The following is a description of a gene set: Transcription regulation during the cell cycle is crucial for ensuring genes are expressed at the right time and in the correct amounts, coordinating key processes like DNA replication, mitosis, and cell division. In our study, studied in species Homo sapiens Human Gene Set: PULVER_FOREY_CELLCYCLE_PEAKING_S2 Genes whose expression fluctuates during the cell cycle (pVal < 0.05) and peaks in late S (S2) in K562, and this is the list of marker genes: CNNM3, ITM2A, ALDH1A2, CCDC43, MAP3K1, SPC24, FARS2 (phenylalanyl-tRNA synthetase 2, mitochondrial), GPR55, DHRS13, GPATCH8, CENPO, HAUS4, PBRM1, THAP11, RBM6, GMEB1, DNAJB12, MSH5, SMC1A, LINC01804, PTPN11, CYB5B, PCNP, XPO6, XRCC1, PPP5C, SUSD1, TNRC6C, IWS1, RNF213, GABPB2, BNIP1, ASAP2, H1-5, CZIB, STAT3, PRKCQ, ANKRD13A, BNIP3, TFIP11, SCG5, RAD54L2, PPP6R3, WASF1, CEP128, TRDMT1, PLIN2, SLC1A5, POP1, PANK4, PPP2R3C, AKAP8, SLC1A4, ZNF653, CTCFL, STX2, TTC31, ADARB1, CMC2, TMEM98, MRPL37, AP2A1, AARS2, CDK4, MYB, LRP8, CENPJ, ADRA1D, AGO2, RAVER1, DOLPP1, GRIN1, HROB, NONO, METTL3, DDX17, ANP32B, TRIP13, RNF168, FBXO48, HAUS5, STK35, KAT6A, CCDC22, PUF60, GEMIN4, SUMO3, TNFRSF1B, CPNE2, MTO1, PXMP4, ELP6, EEF1A2, NUP42, CHAC1 (ChaC glutathione specific gamma-glutamylcyclotransferase 1), TUBB, NEMP2, CDK5RAP2, UTP25, CTCF, FBXL14, LRRC8D, TYMSOS, GID8, HAUS8, NAT10 (N-acetyltransferase 10, NCBI Gene Id 79715), KIF15, PIP4P1, KAT5, SENP1, AP5S1, SPC25, DENND4B, GGA3, PEG10, CHRAC1, UBR4, SAE1, SEMA4D, TEDC1, SPOP, QSOX2, SF3A2, TRNAU1AP, JOSD1, NSD2, FAF2, H2AZ1, AMOTL1, GRK2, KATNB1, KEAP1, CBFB, H2AC21, GBF1, ZNF784, ZNF764, LIN9, SLC43A3, H3C4, ATF6, NUP107, TMEM39B, LUC7L, EXT2, ILF3, TBC1D10B, KBTBD2, ADRM1, CTIF, CKB, FANCC, PIGS, TDP2, PCBP1, METTL25B, TANC2, H1-2 (NCBI Gene Id 3006), HASPIN, CHTOP, ADAM9, RMDN3, PTPRA, XRCC4, MYRIP, JADE1, NET1, SASS6, IMMT, PPDPF, H4C11, FOXM1, GPR89B, TRAIP, HTRA3, ASAP1, CPED1, TIMELESS, SLC25A17, NUP50, ITPRIP, C5orf34, MGME1, METTL1, CCDC150, ASNS, RFX3, SNRNP200 (small nuclear ribonucleoprotein U5 subunit 200), HTRA2, CXCL3, GMEB2, DYNC2I2, RBPMS2, SCAMP2, STAG1, SKA3, CLASRP, B4GALT1, EXTL3, EMC1, SRSF4, CENPN, KANSL1, USP10, WDR1, HIRIP3 (HIRA interacting protein 3), NRSN2, PPM1G, RGS12, NUP133, AMPD3, TMEM203, C19orf48P, LTBP1, DLG1, PPP1R14C, H3C14, ZFX, POGZ, PABIR1, JUND, DHRS7B (dehydrogenase/reductase 7B), UBE2I, EPB42, TAL2, CDCP1, TMED1, SCAF8, FBXO5, C14orf93, CHST3, USP11, ERCC6L, TNFAIP3, UBBP4, LMTK2, CEP135, ANKFY1, EMG1, ZNF598, GPAT4, RNASEH2A, PIGO, FANCD2, KANSL3, CPSF4, PRSS12, YY1AP1, RBM47, PBK, ACO2, ATRIP, PIM1, TINF2, GTPBP3, XPO7, DXO, GAMT, RAD23A, MYO18A, NRGN, CPXM1, ZNF627, ZNF689, INTS5, SLC37A4, NIPAL3, TMEM175, PRTFDC1, ASF1B, GABPB1, KIR3DL3, XPC, TUBA4A, TSTD2, MFN2, CDCA4, CAMSAP1, MRPS7, ASH2L, WDR54, BLTP3A, TRAK2, PLK4, SRP68, HPS4, KIF24, EXOSC10, GPHN, GLE1, INTS6L, SRRD, BEX4 (NCBI Gene Id 56271), RANBP1, TTF2, VPS13D, C6orf136, REXO5, RUNX1, PDZD8, PSMD11, PHKA2, ZNF740, MTFR2, DHX30, ERAL1, H2BC12, DNAJC6 (DnaJ heat shock protein family (Hsp40) member C6), ARSG, PPFIBP2, INIP, MED11, CEBPB, KLF1 (NCBI Gene Id 8055), NUP153, MTFP1, OR2B6, MEA1, GLYCTK, RAPGEF6, CENPV, CD164, H3C15 (NCBI Gene Id 449003), TUBGCP4, ASXL2, ADGRV1 (NCBI Gene Id 84059), RPS5 (ribosomal protein S5), PAF1, ACOT7, MAN2A2, HCFC1, CR1L, NCR1, ATPSCKMT, ST8SIA6, RAF1, DYRK1A (NCBI Gene Id 1859), PUM1, FAM124B, PCM1, CPOX, TLE3, DHRS2, SUPT7L, SCMH1, GBA2, SQLE, NEIL3, PSMC5, H2BC4, UQCC3, SP8, ADAM17, EEF2K, CDKN2D, LDLRAD3, TRRAP, GRWD1, PTBP1, POLQ, PRR14L, NOP9, POLR3A, SLC17A7, ACTB, SF3A1, FAF1, GNE, FYCO1, FAM20B, SETD1A, MIB1, NFATC2, ATXN2L, CDCA5, EIF3A, CGREF1, HMGA1, ASH1L, PIK3CB, ZNF592, ST6GALNAC1, PI4KA, INO80, TMEM237, POLR3E, NUP210 (nucleoporin 210), TUBA1B (NCBI Gene Id 88851), APOBEC3B, SEPTIN5, ELOVL2 (NCBI Gene Id 54898), ST6GAL1, ZBTB45, MEAF6, SSRP1, TRARG1 (trafficking regulator of GLUT4 (SLC2A4) 1), E2F6, EIF2S3B, RPS2, MYBL2, DUSP12, SRRM2, HSPA9, TAF1, ZKSCAN2, PSME3IP1, CEP295, POLE3, KLHDC3, C1orf226, SEL1L3, USP4, WSB2, RBM22, EHBP1, DEDD, KIAA1328, PCIF1, ABCC5, AGPAT2, MELK, RHOG, EIF3D, INTS2, POLD1, CNNM4, SF3B2, CLN6, TICRR, CSE1L, METTL23, AFDN, TRIOBP, SMPD4, CMTM4, USP21, CEBPG, MARCHF6, TLCD3B, AARS1, PRPF8, WSCD2, TTLL4, PEX11B, AKAP1, DST, BEND3, RASAL2, THRAP3, SUDS3, ECE1, LRR1, ZNF619, TMPO, SHMT2, CLIC4, AMMECR1L, C21orf58, CLEC16A, C8orf74, TUBA3C, HNRNPL, KLF9, ABCB10, DHRS3, NFYC, SF3B3, CLSTN1, TRA2A, TXNRD1, ATG10, EIF4A3, SUV39H1, UBAC1, H2BC15, PCBD2, ORMDL2, GLB1L2, SLC22A5, UQCC1, CENPL, SHCBP1, NSUN4, NGDN, ZNF239, ZBED4, RALY, ELF4, GARS1 (NCBI Gene Id 7972), CDK12, ZNF331, GLA, KPNB1, PSMA7, NELFCD, IKZF4, MICU2, SLC25A5, RHD, TNS4, TMEM14EP, DIAPH3, NUP88, NUDC, NCAPG2, P2RX5-TAX1BP3, UBE2M, KIF5B, PGBD2, ARID1A, USP32, FBN1, COLGALT1, H3-3B, CNOT1, FNTB, NEURL4, PCNT, MDC1, EDC4, YWHAH, LRCH3, SPTB (spectrin beta, erythrocytic), CAMK2D, PAAF1, KAT8, C17orf75, ACAD9, LRRC51, TAF6L, AKNA, MTHFD2, CTC1, HMBS, NOM1, SMG9, ZRANB3 (NCBI Gene Id 84083), SRCAP, RIPOR3, TECR, H2AC25, HMGN2, POMK, ELAVL1, TUBG1, DHCR7, OPA3, RFX1, SPIDR, PGAM4, DDX28, SLC7A1, CIP2A, SMC4, ING1, LPIN1, SH3BP4, SLC48A1, DDIT4, AHCY, CELF1 (NCBI Gene Id 10658), FANCI, HADH, OGDH, RBM15, PATL1, NUP188 (nucleoporin 188), MUS81, SLC22A23, ZNF274, FKBPL, MBLAC1, H1-10, PAX6 (paired box 6), TMEM97, NUP205, NSD1, EPRS1, ZBTB5, EP300, TMCO4, INSIG1, SKA1, RCE1, ANKRD40, VAPA, RBM23, ZBED5, TRAK1, DDX23, DET1, H2AC20, MPHOSPH9 (NCBI Gene Id 64797), PHPT1, HCN2, GAB3, H3-5, CEP350, TBP, C11orf96, RRAGA, PLCH1, SZRD1, UBE2T (ubiquitin conjugating enzyme E2 T), SMAD2, MTOR, SLC29A1, CBX5 (chromobox 5), TAPT1, NEMP1, FAM234B, MAPK11, ERI2, TCF20, POLDIP3, LIG1, NCAPH2, ATP1A3, TK1, HNRNPLL, UROS, UNK, TERF2, FKRP, SRXN1, MAPRE1, CCDC34, PABIR2, IFT56, PIGU, CXCL2, BCL7A, STIL